The following is a description of a gene set: Human Gene Set: GSE8384_CTRL_VS_B_ABORTUS_4H_MAC_CELL_LINE_DN species: Homo sapiens Genes down-regulated in comparison of control RAW264.7 cells (macrophages) versus those infected with B. abortus. from publication Eskra L, Mathison A, Splitter G (PMID 12595423) Identification of host responses at the gene transcription level provides a molecular profile of the events that occur following infection. Brucella abortus is a facultative intracellular pathogen of macrophages that induces chronic infection in humans and domestic animals. Using microarray technology, the response of macrophages 4 hours following B. abortus infection was analyzed to identify early intracellular infection events that occur in macrophages. Of the more than genes, we identified over genes that were reproducibly differentially transcribed. First, an increase in the transcription of a number of pro-inflammatory cytokines and chemokines, such as TNF-α, IL-1β, IL-1α, and members of the SCY family of proteins, was evident that may constitute a general host recruitment of antibacterial defenses. Alternatively, Brucella may subvert newly arriving macrophages for additional intracellular infection. Second, transcription of receptors and cytokines associated with antigen presentation, e.g., MHC class II and IL-12p40, were not evident at this 4 hour period of infection. Third, Brucella inhibited transcription of various host genes involved in apoptosis, cell cycling, and intracellular vesicular trafficking. Identification of macrophage genes whose transcription was inhibited suggests that Brucella utilizes specific mechanisms to target certain cell pathways. In conclusion, these data suggest that B. abortus can alter macrophage pathways to recruit additional macrophages for future infection while simultaneously inhibiting apoptosis and innate immune mechanisms within the macrophage permitting intracellular survival of the bacterium. These results provide insights into the pathogenic strategies used by Brucella to survive long-term within a hostile environment., and this is the list of marker genes: TLE3, ZFP36 (ZFP36 ring finger protein), PIM3, MRFAP1L1, SH2B1, CHD8, LRRC8A, RABEPK, KRTAP20-2, ASH1L, HIPK1, THUMPD1, DGAT1, ECI1, DUSP1, GTF3C1, LIPE, SLC25A17, MINDY1, SERPINE1, TNIP1, RRAGD, CXCL10, CHD7, NFKBIA, PROCR, IFIT1B, ARRDC4, PAFAH2, TOP3B, C5AR1, KPNA6, DHRSX, STAT5A, ETS2, BBS9, GTF2F2, RRN3, MAP2K3, SERPINB2, DDA1, FBXL15, PLAUR, PIM1, CNR2, BCL3, GPSM3, STX8, MMP9, NDUFA10, GLRX, PLEC, DNAAF10, COX4I1, ITPK1, TIAM1, DDX19B, POLR1B, BLCAP, PEX5, NFKB2, RPF2, NFKBIZ, PPIA, NTHL1 (nth like DNA glycosylase 1), HBEGF, IL5RA, LTB, EFL1, TNNC1, PER1, NR1D1 (NCBI Gene Id 9572), SURF4, CLCN5, ORM1, GMPPB, RALGPS2, UBE2O, DDIT3, TRAF2, IER3, SLC2A5, PGP, UROS, ZNFX1 (zinc finger NFX1-type containing 1), CALCRL, MMP13, MAPRE2, HOXB4, UBE4B, MT2A, IDH3A, GPAT4, RPS6KA2, STK40, CSF3 (colony stimulating factor 3), MT1E, GGPS1, POLK, DLGAP4, RPLP0, TNFRSF1B, CDKN1A, GADD45A, ZNF146, PTGS2, TRPC6, JARID2, SEMA4B, CCL7, CLPS, MGST1, IL1RN (interleukin 1 receptor antagonist), MED24, E4F1, COMMD5, RELB, ENTPD4, NCKAP1L (NCK associated protein 1 like), CYBB, GNPAT, TNFRSF8, ITGA5 (integrin subunit alpha 5), CCL13, SLFN12L, ZNF821, OS9, R3HCC1, TRAF1, ALDOAP2, TULP2, SLC20A1, SOCS3, COX17, MYL3, PACRGL, CCND1, MYO1C, HMGCR, ANXA6, KDM5D, EHD1, IL1B, IL13RA2, SNTB2, VEGFA, CXCL3, ACTR2, MAEA, CCL4, F3, IL18RAP, OAS1, TXLNG, GADD45B, ARL2BP, MSN, EGR1, TBCB, TNFRSF9, MEA1, DDX49, MEN1, PQBP1, DUSP2, ITSN1, BLZF1, CSNK2A1, ACOD1, CRABP1, ENTPD6, AFF1, ATP5MF, ZBTB17, SNRK, RIMKLB, HPS4 (HPS4 biogenesis of lysosomal organelles complex 3 subunit 2), RALGDS, SQSTM1, RBM4, FUBP1, PSMD9, PXN, HLA-DMA, RNF19B, FMNL1, NGDN, IL1A, GALNT2, CNOT4, TMEM70, TNF, MRPL45, SKIL, PDE1B, SNX17, FURIN, PER2, TSPAN3, SAT1